Given this list of marker genes IL1R2, AMD1, SNX4, PYY, MAPRE2, CLIC2, AMPD1 (adenosine monophosphate deaminase 1), NF2, PRKAG1, ATP5F1C, IGF1, ALDH3A2, NDNF, PTGER2, CEP70, TFAM, IRAG2, FERRY3, PRKACB, FAS, ADAM28, ITM2A, GALNT4, CLINT1, MAP7, GGT1, GCG, LRRC31, RAB27A, CHGA, RNGTT, CPA3, CREBL2, here is a description of the gene set: This study assessed the possibility to build a prognosis predictor, based on microarray gene expression measures, in stage II and III colon cancer patients. Tumour (T) and non-neoplastic mucosa (NM) mRNA samples from 18 patients (nine with a recurrence, nine with no recurrence) were profiled using the Affymetrix HGU133A GeneChip. The k-nearest neighbour method was used for prognosis prediction using T and NM gene expression measures. Six-fold cross-validation was applied to select the number of neighbours and the number of informative genes to include in the predictors. Based on this information, one T-based and one NM-based predictor were proposed and their accuracies were estimated by double cross-validation. In six-fold cross-validation, the lowest numbers of informative genes giving the lowest numbers of false predictions (two out of 18) were 30 and 70 with the T and NM gene expression measures, respectively. A 30-gene T-based predictor and a 70-gene NM-based predictor were then built, with estimated accuracies of 78 and 83%, respectively. This study suggests that one can build an accurate prognosis predictor for stage II and III colon cancer patients, based on gene expression measures, and one can use either tumour or non-neoplastic mucosa for this purpose. studied in species Homo sapiens Human Gene Set: BARRIER_CANCER_RELAPSE_NORMAL_SAMPLE_UP from publication Barrier A, Lemoine A, Boelle PY, Tse C, Brault D, Chiappini F, Breittschneider J, Lacaine F, Houry S, Huguier M, Van der Laan MJ, Speed T, Debuire B, Flahault A, Dudoit S (PMID 16091735) Up-regulated genes in non-neoplastic mucosa samples from colon cancer patients who developed recurrence of the disease.